Given this list of marker genes Arrb2, Itgb3, Oprl1, Cstl1, Sigmar1, Cacna1a, Adcy8, Oprd1, Oprk1, Ppp1r9b (NCBI Gene Id 217124), Penk, Oprm1, Syp, here is a description of the gene set: Mouse Gene Set: GOBP_G_PROTEIN_COUPLED_OPIOID_RECEPTOR_SIGNALING_PATHWAY studied in species Mus musculus A G protein-coupled receptor signaling pathway initiated by an opioid binding to its receptor on the surface of a target cell, and ending with the regulation of a downstream cellular process.